Given this list of marker genes FYN, GOLGA2P5, ANXA4, GAS2L3, NQO1, ATL3, KCNE3, ALDH3A2, SLC7A8, PSKH2, ITPKB, FBXL20, MPZL3, MYADML2, SHISAL1, AMPH, ERO1A, SMPDL3A, SGK1, SPOPL, TMEM255A, BRCA2, STOM, RAB6A, GPAT3, TMPO-AS1, TNS3, RGS18 (NCBI Gene Id 92122), GIMAP2, SPACA3, TRIM14, TLE4, PRR9, LINC00934, DOCK2, DDAH2 (NCBI Gene Id 23564), APAF1, SCAMP1-AS1, NAGK, TRIB2, UCN2, H2BC12L, TLR1, KLF3-AS1, FCHO2, BMPR2, PSAT1, RBM41, CECR3, GHR, HNMT, CD68, CCR1, THEMIS2, SFMBT2, EGR2, SYK, PARPBP, TM9SF2, SDC2, HES7, CMIP, THBS1, NT5C2, ANKRD33, TMCC1, CLN8, FPR3, SNTB2, ALOX15, KCNK4, LINC00304, PKIB, PGM2L1, FBXL16, ORMDL3 (NCBI Gene Id 94103), IFNAR2, COL25A1, CTLA4, ELAC2, SSTR5-AS1, CFAP74, ZNF362, LINC00485, MRNIP, GSAP, FMNL2, PDCD4-AS1, SLC38A6, TNFSF13, ZNF234, TSPEAR, EPDR1, CDH26, LORICRIN, EWSAT1, SAMHD1, FADS2, MAF, AFMID, ADISSP, LMTK2, LHFPL2, SGPP1, EXOSC6, FCHSD1, ZNF570, NOS1AP, RERE, CLIP4, LIPT2-AS1, CDC25B, MSH2, PRKCA, CXCL16, CISD3, NOPCHAP1, ZNF786, SMCHD1, FUT9, NCSTN, LCTL, CSF1R, ALG10B, SLC29A3, SIAH3, WSB1, PLAU, FHIP1B, SLC41A3, CBX2, ARHGEF17, IFNGR2, PAPSS1, MFAP5, RBM47, NPBWR1, SMIM17, PCYT1B, LEPROTL1, ANTKMT, GSDMC, CTNS, GIPC3, CPB2, BCO2 (NCBI Gene Id 83875), ADORA3, RAB43, FBN3, USP44, NFIL3, ZNF620, ANKMY1, CCDC121, ZNF527, CMTM8, ENSG00000255428, H3C10, SGTB, CCN4, LACC1, TNFRSF19, ZP4, LINC01126 (long intergenic non-protein coding RNA 1126), FYB1, HMOX1, GLUL, CHGA (NCBI Gene Id 1113), TPST2, ZNF34, GMPR, GPR160, CRNN, TIMP3 (TIMP metallopeptidase inhibitor 3), TSGA13, TBC1D8, FGL2, SH3GL2, ITIH1, RPL39L, EPHX2, ME1, LINC01913, AHR, KBTBD6, RCN2 (reticulocalbin 2), ARL4C, MYO1F, TMPRSS11B, here is a description of the gene set: Genes up-regulated in comparison of dendritic cells (DC) stimulated with R848 at 8 h versus DCs stimulated with LPS (TLR4 agonist) and R848 for 8 h. from publication Napolitani G, Rinaldi A, Bertoni F, Sallusto F, Lanzavecchia A (PMID 15995707) studied in species Homo sapiens Toll like receptors (TLRs) sense microbial products and initiate adaptive immune responses by activating dendritic cells (DCs). Since pathogens may contain several agonists we asked whether different TLRs may synergize in DC activation. We report that in human and mouse DC TLR3 or TLR4 potently synergize with TLR7, TLR8 or TLR9 in the induction of selected cytokine genes. Upon synergistic stimulation, IL-12, IL-23 and Delta-4 are induced at levels 50-100 fold higher than those induced by optimal concentrations of single agonists, leading to enhanced and sustained TH1 polarizing capacity. Using microarray analysis we show that only 1.5% of the transcripts induced by single TLR agonists are synergistically regulated by combinations of TLR4 and TLR8 agonists. These results identify a combinatorial code by which DCs discriminate pathogens and provide (suggest) a rationale to design adjuvants for TH1 responses. Series_overall_design: 3 untreated, 3 treated with LPS at 2h, 3 treated with LPS at 8h, 3 treated with R848 at 2h, 3 treated with R848 at 8h, 3 treated with LPS + R848 at 2h, 3 treated with LPS + R848 at 8h Human Gene Set: GSE2706_R848_VS_R848_AND_LPS_8H_STIM_DC_UP